The following is a description of a gene set: from publication Schaefer CF, Anthony K, Krupa S, Buchoff J, Day M, Hannay T, Buetow KH (PMID 18832364) Human Gene Set: PID_NFKAPPAB_CANONICAL_PATHWAY species: Homo sapiens Canonical NF-kappaB pathway, and this is the list of marker genes: UBE2D3, RIPK2 (NCBI Gene Id 8767), XPO1, TNFAIP3, NFKBIA, RELA, BCL10, PRKCA, IKBKG, TNFRSF1A, CHUK, CYLD, BIRC2, TNF, TRAF6, ERC1, NOD2, ATM, IKBKB, SSPOP, MALT1, NFKB1, RAN